The following is a description of a gene set: species: Mus musculus Mouse Gene Set: MCDOWELL_ACUTE_LUNG_INJURY_DN Genes down-regulated in the mouse model of acute lung injury induced by inhaling nickel sulfate. The role of nitric oxide (NO) in acute lung injury remains controversial. Although inhaled NO increases oxygenation in clinical trials, inhibiting NO-synthase (NOS) can be protective. To examine the latter, nickel-exposed mice were treated with saline or NOS inhibitor, N(G)-nitro-L-arginine methyl ester (L-NAME). Initial microarray analysis of nickel-induced gene expression of saline-treated mice revealed increased inflammatory mediator, matrix injury-repair, and hypoxia-induced factor-mediated sequences and decreased lung-specific (e.g., surfactant-associated protein B and C) sequences. Compared with saline control, L-NAME-treated mice had enhanced survival with attenuated serum nitrate/nitrite, endothelial NOS activity, and lavage neutrophils and protein. Although initial cytokine (i.e., interferon-gamma, interleukins-1beta and -6, macrophage inflammatory protein-2, monocyte chemotactic protein-1, and tumor necrosis factor-alpha) gene expression was similar between groups, subsequent larger cytokine increases only occurred in saline-treated mice. Similarly, surfactant protein gene expression decreased initially in both groups yet was restored subsequently with L-NAME treatment. Interestingly, the role of inducible NOS (iNOS) in these responses seems minimal. iNOS gene expression was unaltered, iNOS activity and nitrotyrosine residues were undetectable, and an iNOS antagonist, aminoguanidine, failed to increase survival. Rather, systemic L-NAME treatment appears to attenuate pulmonary endothelial NOS activity, subsequent cytokine expression, inflammation, and protein permeability, and thereby restores surfactant gene expression and increases survival. from publication McDowell SA, Gammon K, Zingarelli B, Bachurski CJ, Aronow BJ, Prows DR, Leikauf GD (PMID 12540486), and this is the list of marker genes: Adh1, Pde4dip, Fgf1, Nrp1, Dpp4, Icam2, Cxcl12, Trp53bp2, Fasn, Rbp1, Meox2, Nfix, Clec10a, Mapt, Apln, Llgl2, Pon1, Timm17a, Adgre5, Hc, Bmp2k, Antxr1, Zbp1, Acvrl1, Mrps18b, Hey1, Chst2, Thbs3, Epb41l3, Alas1, Pex16, Cdh13, Abcg1, Ogt, Rsu1, Sftpb, Sftpc, Cdkl2, H2-Eb1, Cyp2f2, Nherf2, Scgb3a2 (NCBI Gene Id 117158), Fhl1, Cav1, Ltbp4, Tnfrsf19, Aplnr (apelin receptor)